The following is a description of a gene set: Myeloid ELF1-like factor (MEF), also known as ELF4, is a member of the ETS family of transcription factors which is expressed in hematopoietic cells. MEF-deficient mice have defects in natural killer cell and natural killer T cell development, suggesting a role for MEF in regulating innate immunity. MEF also functions in myeloid cells, where it can transactivate target genes. To identify MEF target genes in a myeloid environment, we created an inducible expression system and used oligonucleotide microarrays to examine the transcript profile of HEL cells after induction of MEF expression. Sixteen genes were reproducibly turned on or off more than 2-fold, 8 h after induction of MEF expression, and we examined one of the genes, interleukin-8 (IL-8), in greater detail. IL-8 is a CXC chemokine involved in neutrophil chemoattraction, angiogenesis, and stem cell mobilization. It is expressed by several tumor types, and its expression is regulated primarily transcriptionally. The IL-8 promoter contains three ETS binding sites, and we identified the specific site that binds MEF and is required for MEF responsiveness. MEF, but not the closely related ETS factors PEA3, ETS1, ETS2, ELF1, or PU.1, strongly activates the IL-8 promoter. MEF overexpression is sufficient to induce IL-8 protein expression, and reduction in MEF expression (using RNA interference) results in decreased IL-8 levels. These data demonstrates that MEF is an important regulator of IL-8 expression. Genes up-regulated in HEL cells (erythroleukemia) upon expression of ELF4. studied in species Homo sapiens Human Gene Set: HEDVAT_ELF4_TARGETS_UP from publication Hedvat CV, Yao J, Sokolic RA, Nimer SD (PMID 14625302), and this is the list of marker genes: CREM, TAF7, MT1G, CXCL8, PIK3C3, CXCL2, CA2, KIT, HDC, ABCB1, NDUFS8, RCAN1